Given this list of marker genes DDR2, TRPV4, FKBP14, DYM, COL2A1, ARSL, here is a description of the gene set: Human Gene Set: HP_ATLANTOAXIAL_INSTABILITY Atlantoaxial instability Abnormally increased movement at the junction between the first cervical (atlas) and the second cervical (axis) vertebrae as a result of either a bony or ligamentous anomaly. species: Homo sapiens